Given this list of marker genes CTSA, NEU1, GLB1, here is a description of the gene set: species: Homo sapiens Sialidases have important roles in the degradation of glycoconjugates by removing terminal sialic acid residues.<br>Defects in sialidase 1 (NEU1) cause sialidosis, a lysosomal storage disease characterised by the progressive lysosomal storage of sialidated glycopeptides and oligosaccharides and the accumulation and excretion of N-acetylneuraminic acid (Neu5Ac) covalently-linked ('bound') glycoconjugates (Lowden & O'Brien 1979). The sialidoses are distinct from the sialurias in which there is storage and excretion of 'free' Neu5Ac. Sialidosis manifests into types I and II forms. Type I is the milder form, also known as the 'normosomatic' type or the cherry red spot-myoclonus syndrome. Sialidosis type II is the more severe form with an earlier onset, and is also known as the 'dysmorphic' type. part of: Diseases associated with N-glycosylation of proteins Reactome Pathway: Defective NEU1 causes sialidosis